The following is a description of a gene set: species: Homo sapiens Human Gene Set: MODULE_396 Genes in the cancer module 396., and this is the list of marker genes: GABRA6, GLRB, GABRA2, GLRA2, GABRA3, CLCN3, FXYD3, CLCNKA, GABRG2, SLC26A3, CLIC2, SLC12A2